The following is a description of a gene set: Human Gene Set: GOBP_NEGATIVE_REGULATION_OF_ENDOTHELIAL_CELL_PROLIFERATION species: Homo sapiens Any process that stops, prevents, or reduces the rate or extent of endothelial cell proliferation., and this is the list of marker genes: MIR30E, MIR29C, MEF2C, MIR21 (NCBI Gene Id 406991), CCL2, MIR24-1, MIR193A, STAT1, KRIT1, THBS1, NF1, MIR503, MIR34A, TGFBR1, IL12A, MIR492, MIR149, SYNJ2BP, MIR205, MIR133B, NR2F2, MIR132, MIR487B, MIR16-1, VASH1 (NCBI Gene Id 22846), RGCC, CNMD, SPARC, MIR497, GHRL, ENG, PDCD10, MMRN2, IL12B, MIR15B, ACVRL1, APOH, MIR92A1 (microRNA 92a-1), ATP5F1A, MIR98, MIR342, MIR152, DLL4, MIR410, MIR22, TNF, MIR20B, TNMD, PTPRM, CAV1, PPARG, MIR146A, MIR222, ALOX5, MIR494, MIR483, CXCR3, GDF2, MIR129-1, MIR329-1, MIR30B, MIR495, COL4A3, FLT1, APOE, MIR361, SULF1, MIR424, ATP5IF1, PRL, NGFR, CAV2, SCG2, ATOH8, MIR15A, AIMP1, MIR26A1, MIR2355, MIR126